The following is a description of a gene set: Mouse Gene Set: GOBP_POSITIVE_REGULATION_OF_MITOTIC_CELL_CYCLE_PHASE_TRANSITION Any process that activates or increases the frequency, rate or extent of mitotic cell cycle phase transition. species: Mus musculus, and this is the list of marker genes: Lmnb1, Lsm11, Mad1l1, Tgfb1, Camk2d, Adam17, Tmod3, Lsm10, Plcb1, Vps4b, Adamts1, Anapc7, Fbxo5, Aif1, Cul4a, Rab11a, Fgf10, Hspa2, Cpsf3, Rrm2, Ankrd17, Ska1, Rgcc, Cdk4 (cyclin dependent kinase 4), Birc5 (baculoviral IAP repeat-containing 5), Cenpj, Tfdp1, Ska3, Kmt2e, Ccnb1-ps, Anapc11, Neurog1, Mta3, Rb1, Ccne2, Kcna5, Ccnd1, Crebbp, Anapc5, Rad51c, Larp7 (La ribonucleoprotein 7, transcriptional regulator), Cyp1a1, Ddr2, Klhl18, Plrg1, Rdx, Sin3a, Brd4, Ube2e2, Sass6, Cdc25c (cell division cycle 25C), Ddx3x, Rrm1, Cdc7, Wnt10b (wingless-type MMTV integration site family, member 10B), Cenpe, Anxa1, Cdc20, Cdc23, Mepce, Egfr, Rpl17, Ccnd2, Cdc16, Eif4g1, Cdca5, Prap1, Phb2, Mdm2, Cdc25a, Ube2c, Rad51b, Hyal1, D1Pas1, Mir124a-2, Mblac1, Nsmce2, Rrm2b, App, Dbf4, Cdc25b, Rptor, Pbx1, Mir124a-1, Cul3, Smarcd3, Ccnd3, Rcc2, Ccnb1, Anp32b, Apex1, Mir124a-3, Mtbp, Ccne1, Dtl, Cdk1, Stil (Scl/Tal1 interrupting locus), Stox1, Akt1, Tert, Mad2l1bp, Cul4b